Given this list of marker genes SET, PSMB1, COX7C, HDAC2, MORC3, HNRNPK, CALM2 (NCBI Gene Id 805), EIF1AX, KHDRBS1, MDH1, NACA, SNRNP200, PWP1, IFRD1, METAP1, AP3D1, ETF1, CANX, HNRNPH3, RNF4, MRPL9 (mitochondrial ribosomal protein L9), SLC25A5, MARCHF7, FBXW11, DNAJC8, ZNF207, HSPA8, IST1, HADHB (hydroxyacyl-CoA dehydrogenase trifunctional multienzyme complex subunit beta), TAF9, SAFB, HNRNPU, YWHAQ, XPO1, RAF1 (NCBI Gene Id 5894), RTCB, CS, EIF3M, GPAA1, CNBP, PUM1, TCEA1, PSMB7, HNRNPC, RTN4, U2AF1, AATF, AP3S1, PPP2CA, POLR2A, IDH3B, TRAPPC3, NONO, SEPTIN7, CCT2, IK, C1D, STARD7, KARS1, LYPLA1, SSB, CAPZA1, ARFGAP2, ATP6V1F, SLC25A3, ZC3H15, PSMA1, HNRNPA2B1, SDR39U1, PRPF31, VPS26C, CDV3, AFG3L2, HNRNPH2, NAP1L4, RAD21, DDX39A, POM121, POLE3, SUMO2, EIF4H, NCL, CLTC, DHX38, HNRNPAB, KXD1, DNAJC7, G3BP2, NUP188, HTATSF1, TERF2IP, RAP1B (NCBI Gene Id 5908), HNRNPD, RBMX, BZW1, CTDNEP1, RPS27A (NCBI Gene Id 6233), UBE2I, PCMT1, CUL1, TIAL1, PGK1, XPO7, DRG1, FAM168B, GDI2, UBN1, ZZZ3, BECN1, TARDBP, ILF2, PSMA4, CAPZB, LRPPRC, GMFB, GPN1, DEK, RNPS1, UBE2L3, XPO6, HNRNPM, GAK, PUF60, SMNDC1, SON, FOXJ3, BRD8, PIN1, SEC61B, here is a description of the gene set: Neighborhood of PPP2CA protein phosphatase 2 (formerly 2A), catalytic subunit, alpha isoform in the MORF expression compendium Neighborhood of PPP2CA studied in species Homo sapiens Human Gene Set: MORF_PPP2CA